Given this list of marker genes Il6st, Map2k1, Il6ra, Ptpn11, Tyk2, Il6, Mapk3, Jak2, Cdk1, here is a description of the gene set: Mouse Gene Set: REACTOME_MAPK3_ERK1_ACTIVATION studied in species Mus musculus MAPK3 (ERK1) activation